Given this list of marker genes IFNB1, TAF7, NLRP12, NLRC5, IFNL1, CIITA, IL33, HSPH1, here is a description of the gene set: Human Gene Set: GOBP_MHC_CLASS_I_BIOSYNTHETIC_PROCESS The chemical reactions and pathways resulting in the formation of major histocompatibility protein class I. species: Homo sapiens